Given this list of marker genes ST8SIA1 (ST8 alpha-N-acetyl-neuraminide alpha-2,8-sialyltransferase 1), API5, UEVLD, PGRMC2, USP46 (NCBI Gene Id 64854), CDK14, TRIM29, ZNF24, CDO1, TNPO1, DNAH12, VCF1, ZNF264, LPIN2, PPM1D, FHIP2A, RALYL, PTCHD1 (patched domain containing 1), RADX, FSBP, SEC63, MS4A8, SECISBP2, PIGA, PAN3 (NCBI Gene Id 376186), ZNF236, WDR47, MKNK1, CLK1, ZEB1, RANBP17, MAP1B, PPFIA2, CIT, MLC1, SIAH3, VWC2, ACSL6, NUDT4, SERPINA1, CENPE, ANKRD34B, FARP1, BNC2, RILPL2, PABIR3, DEPDC1B, SGCZ, PEX1, CREBRF, CLRN1, PATE4, NUCKS1, CASP10, PRKG1, LYRM7, SDE2, NAPEPLD, LAMP2, GRID2, IRAG1, MANEA, CHRD, NEPRO, KIAA0825, MAGI3, FAM20B, CTSL, GBX2, LMBRD2, UBE2E1, RNF6, AKIRIN2, RYBP, NEUROD4, PITPNA, TRIO, SSX2IP (NCBI Gene Id 22892), RAB22A, DIDO1, GAREM1, TSHZ1, GRM3, FAM120AOS, DOCK5, NPAS3 (NCBI Gene Id 64067), KDM4D, ARL15, PCBP2, HNRNPR, LRCH1, SLC6A16, RNF138, CNOT4, SETBP1, CRK, GAS2L3, FAM216B, MAP3K19, DCX, RFX3, PHACTR4, KPNA4, RPS6KA5, HIF1A, SNX18, ZNF566 (NCBI Gene Id 84924), NAT8, RBM5, UPP2, SAP30L, CSTF2, SHROOM3, PHF24, UBE2W, RC3H1, TET2, here is a description of the gene set: from publication Chen Y, Wang X (PMID 31504780) species: Homo sapiens Genes predicted to be targets of miRBase v22 microRNA hsa-miR-4499 in miRDB v6.0 with MirTarget v4 prediction scores > 80 (high confidence targets). Human Gene Set: MIR4499